The following is a description of a gene set: Human Gene Set: MORF_BAG5 species: Homo sapiens Neighborhood of BAG5 Neighborhood of BAG5 BCL2-associated athanogene 5 in the MORF expression compendium, and this is the list of marker genes: GMFB, PUF60, PSMB4, SRP9, COPS5, MYL11, PSMC2 (proteasome 26S subunit, ATPase 2), PPP1R7, SETD3, BANF1, UBA1, NEDD8, CANX (NCBI Gene Id 821), SUMO1, IST1, MBD4, JTB, RAB5A, COX7A2L, RPL36AL, RAB11A, KARS1, PSMC1 (NCBI Gene Id 5700), HNRNPUL1, ADAR, PSMD7 (proteasome 26S subunit, non-ATPase 7), SYPL1, SYNCRIP, STARD7, ENSA, SKP1, AP2M1 (adaptor related protein complex 2 subunit mu 1), CNBP, TIAL1, COIL (coilin), IK, PDCD6, RAD23B, URM1, PRMT1, BUD31, SP3, EBAG9, COX4I1, FAM120A, EEF1D, TMED2 (NCBI Gene Id 10959), ATP6V1G1, CTCF, ARFGAP2, YWHAB, DNPEP, TBCB, VCP (valosin containing protein), BAG5